The following is a description of a gene set: A G protein-coupled receptor signaling pathway initiated by endothelin binding to its receptor on the surface of a target cell, and ending with the regulation of a downstream cellular process, e.g. transcription. Mouse Gene Set: GOBP_ENDOTHELIN_RECEPTOR_SIGNALING_PATHWAY species: Mus musculus, and this is the list of marker genes: Bcar3, Cdc42, Six1, Ednrb, Gna11, Ednra, Bcar1, Crkl, Gnaq, Plcb4, Edn1, Ptk2b